Given this list of marker genes CHST14, DSEL, BCAN, UST, VCAN (versican), CSPG4, NCAN, DCN, CSPG5, DSE, BGN, here is a description of the gene set: species: Homo sapiens Dermatan sulfate biosynthesis Human Gene Set: REACTOME_DERMATAN_SULFATE_BIOSYNTHESIS